Given this list of marker genes CIC, FBN1, SDHD, FIG4, GATA4, CITED2, GATA5, BMPR2, PRKAR1A (NCBI Gene Id 5573), GNPTAB, SMAD6, TLL1, ACTC1, TBX20, SPTBN1, PEX2, GAA, PCSK9, LDLR, BICRA, MYH7, ADNP, APOB, ELN, IDS, MYH6, DDX6, SMAD9, NOTCH1, GATA6 (GATA binding protein 6), ABCG5, SLC25A4, ABCG8, NKX2-5, CWC27, TWIST1 (NCBI Gene Id 7967), NIPBL, RBBP8, MED12 (mediator complex subunit 12), FOCAD, TMEM260 (NCBI Gene Id 54916), SCO2, LDLRAP1, ADAMTS19, here is a description of the gene set: Human Gene Set: HP_ABNORMAL_HEART_SOUND Any abnormal noise generated by the beating heart. Abnormal heart sound species: Homo sapiens